Given this list of marker genes NTRK2, TDRD5, KLHDC1, KLHL23, THAP6, DDHD1, OGT, SRSF5, NUMB, SHTN1, BDNF, UFSP2, CHAMP1, MTNAP1, PRR16, MARK1, WDR26, GRID2, RPRD1A, TRAPPC13, ZNF792 (NCBI Gene Id 126375), POLR3E, DGKE, XKR4, RNF185, NFIB, ELOVL7, TARDBP, TAOK1, FMNL3, HOXD3, DAB2IP, EPM2AIP1, ZFC3H1, TASOR, BCOR, JRKL, MED12L, SRSF2, KLHL2, ZIC4, MCOLN3, CARF, ZNF322, CLU, DIDO1, FABP7, FAM227A, UNC13C, GABRB3, SERPINB8, CPSF6, ARL5A (ADP ribosylation factor like GTPase 5A), RBM26, SEPTIN7 (septin 7), SLC25A32, TMEM47, ZRANB2, here is a description of the gene set: Genes predicted to be targets of miRBase v22 microRNA hsa-miR-9898 in miRDB v6.0 with MirTarget v4 prediction scores > 80 (high confidence targets). species: Homo sapiens Human Gene Set: MIR9898 from publication Chen Y, Wang X (PMID 31504780)